Given this list of marker genes ALG8, RHOG, AXL, CKAP2, PBX1, CD46 (CD46 molecule), LTBP4, GAS2L1, PNPLA6, ANKS1A, RPL4, LTA, CTNNB1, DUSP1, SCN1B, RBL2, CDSN (corneodesmosin), NECTIN2, IGLC1, GAS2, HYAL1, ZNF331, PRKD2, SAMHD1, here is a description of the gene set: from publication Magrangeas F, Nasser V, Avet-Loiseau H, Loriod B, Decaux O, Granjeaud S, Bertucci F, Birnbaum D, Nguyen C, Harousseau JL, Bataille R, Houlgatte R, Minvielle S (PMID 12623842) Although multiple myeloma (MM) is a unique entity, a marked heterogeneity is actually observed among the patients, which has been first related to immunoglobulin (Ig) types and light chain subtypes and more recently to chromosomal abnormalities. To further investigate this genetic heterogeneity, we analyzed gene expression profiles of 92 primary tumors according to their Ig types and light chain subtypes with DNA microarrays. Several clusters of genes involved in various biologic functions such as immune response, cell cycle control, signaling, apoptosis, cell adhesion, and structure significantly discriminated IgA- from IgG-MM. Genes associated with inhibition of differentiation and apoptosis induction were up-regulated while genes associated with immune response, cell cycle control, and apoptosis were down-regulated in IgA-MM. According to the expression of the 61 most discriminating genes, BJ-MM represented a separate subgroup that did not express either the genes characteristic of IgG-MM or those of IgA-MM at a high level. This suggests that transcriptional programs associated to the switch could be maintained up to plasma cell differentiation. Several genes whose products are known to stimulate bone remodeling discriminate between kappa- and lambda-MM. One of these genes, Mip-1alpha, was overexpressed in the kappa subgroup. In addition, we established a strong association (P =.0001) between kappa subgroup expressing high levels of Mip-1alpha and active myeloma bone disease. This study shows that DNA microarrays enable us to perform a molecular dissection of the bioclinical diversity of MM and provide new molecular tools to investigate the pathogenesis of malignant plasma cells. Human Gene Set: MAGRANGEAS_MULTIPLE_MYELOMA_IGLL_VS_IGLK_DN Down-regulated genes discriminating multiple myeloma samples by the ype of immunoglobulin light chain they produce: Ig lambda (IGLL) vs Ig kappa (IGLK). species: Homo sapiens